Given this list of marker genes Syncrip, Ybx1, Slbp, Lsm11, Eri1, Snrpb, here is a description of the gene set: Mouse Gene Set: GOCC_HISTONE_PRE_MRNA_3_END_PROCESSING_COMPLEX A ribonucleoprotein that binds to specific sites in, and is required for cleavage of, the 3'-end of histone pre-mRNAs. The complex contains the U7 snRNP and additional proteins, including the stem-loop binding protein (SLBP) and the exonuclease 3'hExo/Eri-1. species: Mus musculus